Given this list of marker genes Nrp2, Fzd3, Sema3a, Nrp1, Insm1, Phox2b, Ctnnb1, Ascl1, Sema3f, here is a description of the gene set: The process whose specific outcome is the progression of a sympathetic ganglion over time, from its formation to the mature structure. studied in species Mus musculus Mouse Gene Set: GOBP_SYMPATHETIC_GANGLION_DEVELOPMENT